Given this list of marker genes ACTN2, PLEC, MIR199B, EDNRA, POU5F1, ALPK2, FHL2, NPPA, ACADM, MEF2A, TOMM70, NKX2-5, ITGB1, IRX3, MIR499A, MTOR, ENG, BMP7, ATG5, MAPK3, HAND2, TGFB1, MIR195, GATA4, REST (RE1 silencing transcription factor), PRICKLE1, CBY1, WT1, SEMA3C, MAPK1, MYLK3, TBX2, BMP2, NOX4, IFT20, CDK1, CACYBP, SGCD, LRRC10, RARB, MIR133A1, PDLIM5, PAK1, TWIST1, IGF1, C10orf71, TGFB2, DLL1 (NCBI Gene Id 28514), SHOX2, PDCD4, CXADR, EGFR, ASB2, MAML1, ADRA1A, OBSL1, PRKG1, CALR, PITX2, VEGFA, SMAD4, BMP10, RARA, TBX18, RGS2, HES1, MIR1-1, MEF2C, TGFBR3, ARRB2, AKAP6, EDN1, PARP2, FZD7, CSRP3, MYL2, CTDP1, SRF, MYOCD, MIR200B, FOLR1, LARGE1, ALPK3, FOXP1, MYO18B, NRG1, PDGFRA, MYH11, FHOD3, WNT3A, MIR208A, KAT2A, TTN, EOMES, TCAP, EEF1AKMT4-ECE2, SIRT6, SOX17, PDGFRB, EFNB2, ZMPSTE24, GREM1, YY1, MIR24-1, GREB1L, SOX6, MIR204, PPARA, MIR19A, MIR145, CCNB1, SLC9A1, PROX1, VCAM1, MYH6, MIR590, DHX36, DKK1, SLC8A1, GSK3A, INHBA, NRAP, MESP1, NAGLU, HNRNPU, RGS4, BVES, BMPR1A, ISL1, TENM4, SORBS2, NEBL, TBXT, G6PD, COL14A1, SPRY1, HEY2, KDM6B, TSC1 (NCBI Gene Id 7248), NOTCH1, CTCF (CCCTC-binding factor), CDC42, MIR222, MEIS1, SOX18, MIR19B1, NEB, MIR21 (microRNA 21), MIR23A, CITED2, ADPRHL1, BMP4 (bone morphogenetic protein 4), NKX2-6, KCNJ8, PI16, GATA6, SGCB, ACVR1 (NCBI Gene Id 90), RXRB, MYH10, RBPJ, ACTC1, AKAP13, MIR199A1, TBX3, JAG1 (NCBI Gene Id 3715), HDAC3, SIK1, CAV3 (caveolin 3), TBX5, GPER1, FRS2, LMNA, here is a description of the gene set: Human Gene Set: GOBP_CARDIOCYTE_DIFFERENTIATION studied in species Homo sapiens The process in which a relatively unspecialized cell acquires the specialized structural and/or functional features of a cell that will form part of the cardiac organ of an individual.